Given this list of marker genes SCP2, ERLIN1, NINJ2, OSBPL2 (NCBI Gene Id 9885), CAV1, GPR141, OSBPL11, NPC1L1, NPC1, GPR155, TMEM199, CETP, STARD3NL, TMEM97, SULT2B1, APOF, OSBPL8, RORA, OSBPL9, STARD3, PROM2, INSIG2, OSBP2, PMP2, SIDT1, VDAC2, STAR, INSIG1, APOD, APOA2, MINAR2 (membrane integral NOTCH2 associated receptor 2), GRAMD1A, TSPO2, NFE2L1, OSBPL5, SCAP, PTCH1, VDAC1, EPHX1, NR1H3, SCARB2, GRAMD1C, APOC3, ABCA1, ANXA6, SYP, OSBPL6, ABCG1, GAS1, ERLIN2, GPR183, TSPO, RORC, NPC2, SMO, SOAT2 (sterol O-acyltransferase 2), SOAT1, STARD4, CD81, OSBPL1A, OSBP, OSBPL10, OSBPL3, APOA1, PROM1 (prominin 1), STARD5, SLC38A9, OSBPL7, GRAMD1B, here is a description of the gene set: species: Homo sapiens Human Gene Set: GOMF_STEROL_BINDING Binding to a sterol, a steroid containing a hydroxy group in the 3 position, closely related to cholestan-3-ol.